Given this list of marker genes Irak1, Nkiras1, Nfkbib, Rps6ka3, Ppp2r1b, Nkiras2, Tab3, Mapkapk3, Map2k6, Rps6ka2, Casp8 (NCBI Gene Id 12370), Uba52rt, Ppp2r1a, Ubc (ubiquitin C), Peli3, Ikbkg, Jun (NCBI Gene Id 16476), Map2k7, Dusp7 (NCBI Gene Id 235584), Ppp2ca, Ppp2r5d, Ripk2, Mapk8, Tirap, Ppp2cb, Nlrx1, Map3k7, Atf1, Mapk1, Mapk3, Nlrc5 (NLR family, CARD domain containing 5), Dusp3, Rela, Nfkb2, Fbxw11, Ager, Cul1, Rps27a, Vrk3, Ubb, Mapk10, Ube2v1, App, Ecsit, Atf2, Tab1, Traf2, Usp14, Nfkbia, N4bp1, Mapk7, Dusp4, Ikbkb, Map3k8, Hmgb1, Dusp6, Rps6ka1, Chuk, Mapk11, Nod2, Uba52, Fos (FBJ osteosarcoma oncogene), Irak2, Tnip2, Usp18, Map2k4, Nod1, Peli2, Lrrc14, Mapk14, S100b, Ube2n (ubiquitin-conjugating enzyme E2N), Alpk1, Peli1, Map2k3, Nfkb1 (NCBI Gene Id 18033), Mapk9, Rps6ka5, Traf6, Mapkapk2, Creb1, Tab2, Tifa, Skp1, here is a description of the gene set: species: Mus musculus MyD88:MAL(TIRAP) cascade initiated on plasma membrane Mouse Gene Set: REACTOME_MYD88_MAL_TIRAP_CASCADE_INITIATED_ON_PLASMA_MEMBRANE